The following is a description of a gene set: Human Gene Set: MODULE_122 Adhesion molecules. species: Homo sapiens, and this is the list of marker genes: COL5A1, CD2, CDH2, PPBP, MGP, LAMB3, COL3A1 (collagen type III alpha 1 chain), NEO1, COL9A1, COL4A5, CD99, ECM2, MCAM, MFAP5, ICAM4, CD151, FBN1, NRP1, CDH6, IL18, POSTN, PTK7, SPOCK1 (NCBI Gene Id 6695), LAMA2, LAMC2, THBS2, VWF (NCBI Gene Id 7450), LAMB1, CNTNAP1, NCAN, COL5A2, CDH17, TNXB, LGALS7, AMELY, ANOS1, ALCAM, CX3CL1, BGN, CHL1, CDH5, CCL2, DSG3, JAM2, ITGA5, CXCL12, PPFIBP1, PCDH17, MSLN, ITGB5, LAMA5, ADAM12, COL6A2, EFNB1, CDH1, COL6A1, LSAMP (limbic system associated membrane protein), PTPRF, ITGB2, SELP, DDR2, CXCL8, COL9A2, TGFBI, VTN (NCBI Gene Id 7448), ICAM1, COL11A1, COL4A1, ITGAV, NELL1, CCL4, CSF3R, ITGA2, ELN, ISLR, CDH3, ITGAX, OMD, SRPX, ITGAM, CCL11, NCAM1, AOC3, VCAM1, ITGB7, WNT2, COL16A1, FN1, CX3CR1, ITGBL1, CLEC3A, THBS4, PRELP, CD6, PTPRS, DGCR2, TNC (tenascin C), COL1A1, LAMB2, FPR2, L1CAM, FBN2, PECAM1, ARHGDIB, CLDN10, NID1 (NCBI Gene Id 4811), NEDD9, LGALS4 (NCBI Gene Id 3960), CCR1, ITGA3, CCN2 (cellular communication network factor 2), COMP, CDH13 (NCBI Gene Id 1012), RND1, ICAM3, LAMA3, COL9A3, CLDN1, DSG2, RND3, SELL, COL7A1 (collagen type VII alpha 1 chain), COL6A3, ADGRE1, MMRN1, AEBP1, COL12A1, ITGAL, EFEMP2, ZYX, CD5, MFGE8, LY6D, RELN, FAT1, VCL, SSPN, LAMA4, APBA1, COL18A1, EFS